The following is a description of a gene set: Any process that modulates the frequency, rate or extent of bone development. studied in species Homo sapiens Human Gene Set: GOBP_REGULATION_OF_BONE_DEVELOPMENT, and this is the list of marker genes: BGLAP, GLI3, GHRL, LOX, KAT2A, KDR, TMEM119, TNN, TAPT1, GGCX (NCBI Gene Id 2677)